Given this list of marker genes SLC2A10, here is a description of the gene set: Reactome Pathway: Defective SLC2A10 causes arterial tortuosity syndrome (ATS) Four class III facilitative transporters can transport glucose; SLC2A6, 8, 10 and 12 (encoding GLUT6, 8, 10 and 12 respectively). SLC2A10 (located in the Type 2 diabetes-linked region of human chromosome 20q12-13.1) encodes GLUT10, a transporter with high affinity for glucose. GLUT10 is highly expressed in liver and pancreas but is present at lower levels in most tissues. Defects in SLC2A10 are the cause of arterial tortuosity syndrome (ATS), an autosomal recessive disorder of connective tissue characterised by tortuosity and elongation of major arteries, often resulting in death at a young age. studied in species Homo sapiens part of: SLC transporter disorders